The following is a description of a gene set: studied in species Homo sapiens IRE1alpha activates chaperones Human Gene Set: REACTOME_IRE1ALPHA_ACTIVATES_CHAPERONES, and this is the list of marker genes: CXXC1, HDGF, DDX11, EDEM1, SHC1, PLA2G4B, PDIA5, SSR1, LMNA, EXTL1, KDELR3, FKBP14, DNAJB11, PDIA6, CUL7, ADD1, ATP6V0D1, WFS1, GFPT1, TPP1, KLHDC3, MYDGF, DNAJC3, SRPRB, CTDSP2, YIF1A, HYOU1, PPP2R5B, EXTL3, DCTN1, PREB, TLN1, DNAJB9, TSPYL2, SULT1A3, ZBTB17, ACADVL, GOSR2, ARFGAP1, SRPRA, ERN1, HSPA5, GSK3A, SEC31A, WIPI1, XBP1, SYVN1, TATDN2, SERP1, EXTL2